Given this list of marker genes BRSK2, MCF2, KDM1A, PLXNB2, CDH4, RNF6, BCL11A, STK11, ARMCX5-GPRASP2, SCN1B, RAP1A, BDNF, CHN1, TRAK2, AP2A1, SS18L1, FEZF2, TUBB2B, TRPV2, GFAP, PTEN, MAG, BRAF, ADCY6, NTRK3, SYNGAP1 (synaptic Ras GTPase activating protein 1), RAP2A, PUM2, ADGRB3, IL15RA, MYLIP, LZTS1, PTPN1, ADNP, SFRP1, DTNBP1, IL1RAPL1, AMIGO3, ZFYVE27, TLX2, WNT5A, CDH1, LRP8, EFNB3, ARHGAP33, SEMA4D, MAP6, NTNG2, DKK1, PLK5, MBOAT1, KATNB1, S100A9, INPP5F, KHDC3L, ALKAL1, NGF, MIR200C, EP300, STYXL1, COBL, FIGNL2, SPART, PLXNA3, RAPGEF1, PLA2G3, ITPKA, SDC2, CX3CL1, ULK1, DGUOK, HDAC2, PTN, INPP5J, DPYSL5, HES1, PACSIN1, DMD, RAPGEF2, AVIL, CDKL3, DAB2IP, MIR221, NTRK2, CFLAR, SLITRK1, DCC, ZDHHC15, MT3, ALK, SFRP2, ABL1, DIP2B, STMN3, SETX, TSKU, DISC1, PDLIM5, PREX1, APOE, EEF2K, DDR2, NDRG4, CXCL12, LPAR1, SEMA7A, NDEL1, GSK3B, MDM2, KIAA0319, RHOA, FAT3, SEMA3G, CARM1, DPYSL3, GAK, ARSB, SHOC2, NDNF, ANKRD1, DSCAM, PPP3CA, SEZ6, RTCA, AKT1, GPRASP3, NUMBL, DRAXIN, CDKL5, FUT9 (fucosyltransferase 9), CRABP2, PLXNB3, GPC2, PAK2, ITM2C, ARHGAP44, ULK4, NR2E1, CAMK2G, ULK2, RYK, TRIM67, NTRK1 (neurotrophic receptor tyrosine kinase 1), EPHA7, PAK3, NEDD4L, CHRNA3, EFHC2, NEGR1, RTN4R, MACF1, NLGN1, PSEN1, NR2F1, PLXNC1, TENM3, SPOCK1, TBR1, PTK6, DENND5A, MYCBP2, NFATC4, ANKRD27, RTN4IP1, CUX1, ZNF804A, MAP2K1, CAMK1D, P3H1, WNT3, CNTF, NOVA2, CSMD3, NEDD4, PLPPR5, MGARP, SCARB2, MEGF8, NRCAM, DAB2, PTPRD, FKBP4, RAB21, POU4F2, NPTN, TWF1, PTK2B, RGMA, MDK, RET (NCBI Gene Id 5979), RTN4RL2, KNDC1, STK25, CNTN1, ABL2, TNR, TRIM46, SNAP25, THOC2, KIDINS220, SLIT1, EPHB3, HECW1 (NCBI Gene Id 23072), RUFY3, WNT3A, GORASP1, PAK1 (p21 (RAC1) activated kinase 1), MIR431, BMP5 (NCBI Gene Id 653), CAMSAP2 (NCBI Gene Id 23271), PTPRG, NSMF, BAIAP2, DGKG, NEUROG3, STK24, EPO, KREMEN1, LTK, SPP1, KAT2B, FIG4, ATP1B2, SF3A2, CUX2, L1CAM, PTPRS, WASHC5, FGF13, ADCY10, CBFA2T2, NEO1, MAP2, NRDC, CAMK1, SRCIN1, SMURF1 (SMAD specific E3 ubiquitin protein ligase 1), SHANK3, APBB1, FSTL4, FN1, CDK5 (cyclin dependent kinase 5), NCK1, MAPT, CUL7, PPP2R5B, ACP4, ARHGAP35, PPFIA2, MFSD2A, FZD1, MINAR1, EPHA3, NIN, CDC20, ACAP3, SHOX2, TRAK1, SEMA6C, CFL1, EHD1, CD38, BMPR1A, ARHGAP4, RIT2, ROBO1, FES, MIR133B, MAGI2, LRP4, INS, GOLGA4, GRID2 (glutamate ionotropic receptor delta type subunit 2), NRP1, KLF4, VLDLR, VIM, PTK7, CRKL, MIR222, STX1B, KEL, KIF26A (NCBI Gene Id 26153), CAPRIN2, CHODL, HECW2, EFNB2, TWF2, KLK6, SRF, PAFAH1B1, ZEB2, SLIT2, TIAM2, SLC39A12 (solute carrier family 39 member 12), NEU4, BRSK1, TOX, SARM1, RAB29 (RAB29, member RAS oncogene family), SMAD1, FBXW8, FYN, LRIG2, DVL1, FRMD7, PTPRF, ZNF296, TMEM30A (transmembrane protein 30A), KIF21A, ADAM17, MAP2K2, MARK1, PLXND1, PRAG1, RTN4, IST1, TNIK, CNTN2, ITGA3, EPHB2, PQBP1, PARP6, TBX6, YWHAH, CTNNA2, MAP1B, ENC1, PTPN9, SKIL, SEMA3A, TRPV4, LYN, UST, RTN4RL1, SHTN1, ITGA6, TIAM1, ARC, THY1, TRPC6, RAB17, GATA3, IFRD1, ABI3, B2M, PLXNB1, MIR219A1, TNN, NTNG1, CCDC88A, PAQR3, RGS2, LRRK2, TANC2, AMIGO1, EZH2, CRMP1, ANAPC2, FEZ1, SERPINI1, BAG5, NFE2L2, PRKCI, CHRNB2, DHX36, MARK2, METRN, PRRX1, LRRC4C, FZD4 (frizzled class receptor 4), SIPA1L1, FBXO7, ABI2, SNAPIN, DBN1, GRN, LPAR3, EFNA5, HDAC6, LRRC7, TRPC5, FBXO38, CERS2, ATP8A2, ROBO3 (NCBI Gene Id 64221), DAB1, ATOH7, DDX56, CAMK2B, STAU2 (staufen double-stranded RNA binding protein 2), KIF13B, NEFL, WNT7A, TBC1D24, GDI1, SEMA4F, PTPRO, SCARF1, STMN2, XK, SLC30A1, MIR210, BMPR2, SKOR2, SNX3, EPHA4, GFI1, CIB1, ZNF365, GSK3A (glycogen synthase kinase 3 alpha), BMP7, SEMA6D, OBSL1, PMP22, LIMK1, MAP3K13, ISLR2 (immunoglobulin superfamily containing leucine rich repeat 2), TNFRSF12A, NGEF (NCBI Gene Id 25791), PRKD1, ARF6, ALKAL2, SEMA5A, KANK1, CDK5R1, NCKIPSD, NTN1, FGFR1, RETREG3, DDR1 (NCBI Gene Id 780), ATF1, ROBO2, VEGFA, SERPINF1, NCS1, KIF1A, RELN, EFNA1, SEMA3F, CAPRIN1, LZTS3, TMEM106B, CRK (NCBI Gene Id 1398), YTHDF1, RND2 (Rho family GTPase 2), POU3F2, here is a description of the gene set: studied in species Homo sapiens Human Gene Set: GOBP_REGULATION_OF_NEURON_PROJECTION_DEVELOPMENT Any process that modulates the rate, frequency or extent of neuron projection development. Neuron projection development is the process whose specific outcome is the progression of a neuron projection over time, from its formation to the mature structure. A neuron projection is any process extending from a neural cell, such as axons or dendrites (collectively called neurites).